The following is a description of a gene set: Human Gene Set: REACTOME_PREDNISONE_ADME species: Homo sapiens Prednisone ADME, and this is the list of marker genes: UGT1A3, UGT2B17, CYP3A4, AKR1C1, SERPINA6, ALB, ABCB1, UGT2B7, HSD11B1, HSD11B2